The following is a description of a gene set: Mouse Gene Set: GOBP_MITOTIC_CELL_CYCLE studied in species Mus musculus Progression through the phases of the mitotic cell cycle, the most common eukaryotic cell cycle, which canonically comprises four successive phases called G1, S, G2, and M and includes replication of the genome and the subsequent segregation of chromosomes into daughter cells. In some variant cell cycles nuclear replication or nuclear division may not be followed by cell division, or G1 and G2 phases may be absent., and this is the list of marker genes: Mdm2 (transformed mouse 3T3 cell double minute 2), Ube2c, Brca1, Ecd, E2f1, Myo16, Spart (spartin), Plk2, Aurkc, Abraxas2, Cep250, Zfp36l2, Larp7, Gpsm1, Cables1, Exoc6b, Clasp2, Champ1, Tom1l2, Id2, Sptbn1, L3mbtl1, Meioc, Rad50, Exoc3, Enkd1, Nes, Prc1, E4f1, Ankle2, Cntrob, Mir124a-3, Gigyf2, Cdc23, Rpl24, Tpr, Ripor2, Sin3a (NCBI Gene Id 20466), Rnaseh2b, Ezh2, Cdk2, Bub3, Ctnnb1, Ankfn1, Kif2c, D1Pas1, Ptpn3, Pcid2, Actb, Fbxo43 (F-box protein 43), Tubb4b, Myb, Nkx3-1, Cib1, Zmpste24, Mtbp, Rhob, Spc25, Smpd3, Cdk14, Cdc25a, Nup62, Vps4b, Parp3, Pias1, Nae1, Exoc1, Edn1, Mta3, Mnat1, Zfyve19, Bbs4, Usp29, Cav2, Hnrnpu, Asns, Cyp1a1, E2f3, Map3k20, Orc1, Fgfr1, Rpa2, Nabp2, Sirt1, Rps6, Ccne1, Poc1a, Stk35, Azi2, Ckap5, Snhg15, Hsf1, Tbcd, Zw10, Cts7, Kif11, Cul4b, Ush1c, Anapc2, Cdkn1b, Scrib, Rrm2b, Ppp2r3d, Fam110a (family with sequence similarity 110, member A), Nbn, Atf2, Cenpe, Dact1, Ttk, Cdc16, Cyld, Eml4, Becn1, Vps4a, Akap8l, Pkd2, Spry1, Tubgcp5, Nedd1, Ndel1, Ist1, Dapk3, Itgb1, Kntc1, Stag1, Hoxa13, Rab35, Nrde2, Ptpn6, Ccny, Gem, Nsfl1c, Ereg, Smarcd2, Ccnb1-ps, Cenpj, Cdca5, Wee2, Dctn6, Ccnh, Cdk11b, Pcnt, Ccno, Cdkn2d, Pdcd6ip, Kat2b, Psme1, Smc1a, Cks1b (NCBI Gene Id 99474), Acvr1, Igf1, Calm3, Pole, Wdr62, Ccdc8, Anp32b, Wac, Atf6b, Ptpa, Camk2d, Cul3, Bcl7a, Rrm2, Aurka, Plrg1, Naa50, Fam107a, Nipbl, Cenpi, Hnf4a, Met, Sphk1, Mir664, Nek6, Cep55, Pafah1b1 (platelet-activating factor acetylhydrolase, isoform 1b, subunit 1), Trrap, Fbxo31, Dync1h1, Dna2, Setdb2, Hus1, Sh2b1, Rb1, Arf6, Chmp6, Anapc7, Ascl1, Pabir1, Prmt2, Atr, Nudc, Apex1, Kcnh5, Tert, Anln, Brd7, Fgfr2, Arid2, Kpnb1, Cdk7, Uba3, Ankrd53, Nek7, Zc3h12d, Dcun1d3, Cdc26, Smarca5, Prkcq, Senp2, Mcm2, Cks1brt, Usp22, Stk33, Usp37, Foxg1, Taok2, Wrap73, Gins1, Ppm1d, Rbbp8, Rhou, Map1s, Shb, E2f7, Nanog, Tuba8, Rab11fip3, Tnf, Lsm11, Cep97, Rdx, Phf10, Abcb1b, Pkmyt1, Timp2, Ctdsp2, Rnf2, Phf13, Donson, Klhl18, Drd3 (NCBI Gene Id 13490), Firrm, Eme2, Ppp2cb, Mbtps1, Stox1, Arhgef2, Il1a, Hus1b, Bub1b, Actl6b, Dis3l2, Cdc6, Ncapg2, Mad2l1bp, Tom1l1, Pim2, Psmg2, Rtel1, Ints13, Usp47, Hacd1, Bid, Crlf3, Cdk10, Pkhd1, Nfe2l1, Rps6kb1, Syf2, Tuba1c, Rgcc, Eml3, Prdm5, Reep3, Kif15, Lrp5, Cenpf, Asah2, Hmgb1, Myh10, Ttc28, Rfwd3, Tgfa, Chmp2b (NCBI Gene Id 68942), Anapc15, Tubgcp3, Hyal1, Cdk2ap2, Pax6, Rad21, Cdc45, Camk2a, Map10, Snx33, Tuba4a, Ercc2, Bora, Ndp, Arhgef10, Kif2a, Foxo4, Brcc3, Dctn1, Setd2 (SET domain containing 2), Incenp, Pdpn, Pola1, Setmar, Wapl, Mtmr4, Chmp1a, Ccnd1, Kif20a, Sdcbp, Pdik1l, Ttyh1, Lgmn, Ube2srt (ubiquitin-conjugating enzyme E2S, retrotransposed), Lmnb1 (NCBI Gene Id 16906), Ccnjl (NCBI Gene Id 380694), Stag2, Ccnd2, Inhba, Il1b, Nek2, Mcm3, Misp, Rgs14 (regulator of G-protein signaling 14), Ednra (NCBI Gene Id 14737), Cul9, Jtb, Ier3, E2f8, Tacc2, Arhgap33os, Brsk1, Sass6, Reep4, Gins3, Katnb1, Taf2, Ctdsp1, Tubal3, Kif20b, Nasp, Jade1, Cenph, Smarca2, Exoc7, Rps27l, Zfp655, Nfia, Ddb1, Lats2, Rab11a, Rangrf, Anxa1, Tacc1, Iqgap2, Kmt2e, Skp2, Nsl1, Kif18b, Mbtps2, Mki67, Exoc4, Tada2a, Zfp207, Hdac3, Nsmce2, Gen1, Dmrt1, Fbxw5, Trim36, Cacnb4, Dync1li1, Pkd1, Adamts1, Egfr, Ttl, Myc, Ccnj (NCBI Gene Id 240665), Tm4sf5, Psme2, Seh1l, Tuba1a, Rad51b, Bap1, Cdkn2b, Zfp365, Mepce, Calm1, Fzd3, Ncaph, Chmp3, Tacc3, Ccnf, Inppl1, Lzts2, Mir26a-2, Ptpn11, Psrc1, Igf2, Btn2a2, Epgn, Xrcc3, Acvr1b, Tubg2, Kifc1, Atm, Exoc5, Spice1, Bard1, Pim3, Brinp1, Babam1, Stat5a, Tal1, Cdca2, Ticrr, Rprm, Aven, Vcp, Fzr1, Mrnip (NCBI Gene Id 72859), Cenpw, Xrcc2, Ccdc66, Ptprv, Dynlt3, Cdk5rap2, Mir124a-2, Brcc3dc, Mcidas, Nde1, Anapc15-ps, Tgfb1, Smc4, Mis12, Mad1l1, Ins1, Trp53, Prap1, Mapre1, Ank3, Ints3, Bccip, Gja1, Tubd1, Taf10, Mcm6, Tbce, Prkdc, Ska1, Lats1, Ppp2r2d, Mad2l1, Stat5b, Map9, Spdya, Prickle1, Dbf4, Slfn1, Ckap2, Gpr132, Neurog1, Ccdc57, Kcna5, Actl6a, Lig1, Zwilch, Smc2 (structural maintenance of chromosomes 2, NCBI Gene Id 67947), Usp8, Hspa8, Zfyve26, Aatf, Myh14, Cpsf3, Topbp1, Snx18, Prkca, Cltc, Psme3, Ppp2r1a, Nuf2, Cdk5rap3, Mbd4, Knl1, Hspa1a, Fbxl7, Usp44, Ccnd3, Pml, Appl1, Smc3, Map4, Smarcd3, Lipa, Klhdc8b, Egf, Stmn1, Tubb2b, Mcph1 (microcephaly, primary autosomal recessive 1), Rrs1, Kifc5b, Fbxo7, Trp73, Pbx1, Gnai1, Uimc1, Thap1, Eif4e, Pdgfb (platelet derived growth factor, B polypeptide), Tubb2a, Nop53, Ube2a, Foxm1, Cdk6, Ndc80, Snx9, Ran (NCBI Gene Id 19384), Chmp5 (NCBI Gene Id 76959), Cenpt, Tipin, Eif4g1, Tex14, Flna, Id4, E2f6, Brd4, Ccne2, Stx2, Chek2, Ino80, Dusp3, Tube1, Tuba3a, Anapc11, Blm, Ddr2, Pkn2, Sik1, Eml1, Pinx1, Dctn2, Ube2s (ubiquitin-conjugating enzyme E2S), Cdk3, Zfp36l1, Klf11, Tubgcp6 (NCBI Gene Id 328580), Npm2, Chmp7, Gpsm2, Ctdspl, Edn3, Ofd1 (OFD1, centriole and centriolar satellite protein), Appl2, Hspa1b, Camk2b, Trim35, Son, Nek9, Cep85, Stil, Dgkz, Cdc27, Bex4, Cdk1, Cdc25b (cell division cycle 25B), Anapc5 (anaphase-promoting complex subunit 5), Knstrn, Brox, Chmp4c, E2f4, Ptch1, Smarcd1, Rpl17, Phip, Mir124a-1, Ubxn2b, Akap8, Ins2, Kif3b, Brinp3, Arid1a (NCBI Gene Id 93760), Ranbp1, Spc24, Wnk1, Stambp, Rhoc, E2f5, Trim71, Septin7, Kank2, Smarca4, Iqgap1, Nek11, Ncapd3, Cep126, Cd28, Chmp1b2, Bcl7c, Dusp1, Foxc1, Btc, Kif4, Nle1, Ppp3ca, Arl3, Btg4, Fgf8, Cdkn2a, Cenpk, Ythdc2, Sra1, Recql5, Ccng2, Ddx3x, Kif18a, App, Ankrd17, Pdgfrb, Spry2, Klhl22, Ik, Smarce1, Nme6, Mir26b, Tmod3, Ska3, Brsk2, Pibf1, AY074887, Lcmt1, Riok2, Spast, Rcc2, Klf4, Tcf19, Ccsap, Eme1, Rbl2, Calm2, Prpf4b, Ccng1, Tubg1, Cul7 (NCBI Gene Id 66515), Rock1, Chmp1b (charged multivesicular body protein 1B), Brinp2, Tubb1, Rtkn, Chek1, Drg1, Spdl1, Ube2e2, Chmp2a, Nfib, Etaa1, Ska2, Inip, Kif23, Rae1, Taok1, Dpf3, Trim39, Exoc8 (NCBI Gene Id 97490), Kif22, Plk1, Nusap1, Plcb1, Mus81, Abcb1a, Trex1, Bcl7b, Unc119, Adam17, Tubb3, Eps8, Rbm46, Racgap1, Haspin, Brca2, Tunar, Mir26a-1 (microRNA 26a-1), Rptor, Cep192, Ensa, Tuba1b, Smoc2, Esr1, Ttll12, Gjc2, Bub1 (BUB1, mitotic checkpoint serine/threonine kinase), Ywhah, Ovol1, Cdc73, Hinfp, Lsm14a, Heca, Kat5, Dbx2, Ppp1r12a, Bmp4, Cdk4, Cdkn1a, Banf1, Phb2, Afap1l2, Dynlt1b, Ambra1, Dpf1, Pebp1, Ppp1r10, Ctdp1, Mybl1, Plk5 (NCBI Gene Id 216166), Cks2, Ccnb3, Mitd1, Cdca8, Pim1, Wdhd1, Cenpa, Usp26, Kdm8, Aif1, Gas1, Wnt10b, Rcc1, Plk3, Nudt15, Chmp4b, Smarcc2, Cdc7, Fbxw11, Ubd, Dlgap5, Spag5, Xpc, Meis2, Taok3, Ncapd2, Igf1r, Numa1, Bmp7, Usp2, Rbl1, Angel2, Rpa3, Afg2b, Ccdc61, Rad9a (NCBI Gene Id 19367), Mre11a, Arf1, Ilk, Tubb6, Sycp3, Kat14, Cacul1, Eif4ebp1 (NCBI Gene Id 13685), Ppp2ca, Uhrf1, Trip13, Cdc14b, Aaas, Phf8 (NCBI Gene Id 320595), Nabp1, Hspa2, Aurkb, Rad9b, Ccnb1, Pten, Tubgcp4, Bmyc, Abl1, Rtf2, Dlg1, Mybl2, Arpp19, Rrm1, Tpd52l1, Rad17, Mblac1, Wee1, Tk1, Fancd2, Zwint, Cdc20, Btg3, Babam2, Clspn, Daxx, Ercc3, Dpf2, Mastl, Mzt1, Apc, Obsl1, Sbds, Sde2, Rhoa, Ccl12, Foxn3, Dtl, Cul4a, Espl1, Cdt1, Insr, Cdc42, Nfatc1, Ccna1, Pcna, Birc5, D7Ertd443e, Miip, Bcl2, Cenpc1, Akt1, Tfap4 (NCBI Gene Id 83383), Pbrm1, Fhl1, Tpra1, Ctc1 (CTS telomere maintenance complex component 1), Men1, Cdkn2c, Cdc25c, Efhc1, Smarcb1, Smc5, Usp16, Nherf1, Tubb5, Golga2, Creb3l1, Clasp1, Rock2, Cfl1, Nfix, Baz1b, Ube2u, Lsm10, Nek4, Tcf3, Cit, Exoc2, Chfr, Abraxas1, Fgfr3, Tpx2, Gbf1 (NCBI Gene Id 73518), Hes1, Ncapg, Anapc1, Fgf10, Hecw2, Htt, Fsd1, Sapcd2, Ccnb2, Kif14, Mcm4, Rad51, Gpnmb, Pdxp, Cdkn1c, Poldip2, Anapc4, Cdc14a (NCBI Gene Id 229776), Ect2, Pkia (NCBI Gene Id 99614), Ccna2, Rad51c, Ppp6c, Ccni, Fbxl15, Fbxo5, Tjp3, Atad5, Msh2, Zfp830, Iqgap3, Gmnn, Tubb4a, Rint1, Ncaph2, Exoc6, Tfdp1, Smarcc1, Camk2g, Foxa1, Tubgcp2, Khdc3, Ywhae, Tada3, Crebbp